The following is a description of a gene set: Human Gene Set: GOBP_MITOCHONDRIAL_GENOME_MAINTENANCE The maintenance of the structure and integrity of the mitochondrial genome; includes replication and segregation of the mitochondrial chromosome. species: Homo sapiens, and this is the list of marker genes: SSBP1, DNAJA3 (DnaJ heat shock protein family (Hsp40) member A3), MPV17, NEURL4, SLC25A36, MGME1 (NCBI Gene Id 92667), SESN2, TWNK, SLC25A33, AKT3, DNA2, SLC25A4, STOX1, PARP1, LIG3, RRM2B, TYMP, METTL4, POLG, TP53 (NCBI Gene Id 7157), ENDOG, PRIMPOL, POLRMT, RRM1, LONP1, OPA1 (OPA1 mitochondrial dynamin like GTPase), TOP3A, POLG2, TEFM, PIF1 (NCBI Gene Id 89987), MEF2A